Given this list of marker genes Jam3, Cd47, Pdgfd, Ager, Ccr2, here is a description of the gene set: studied in species Mus musculus Mouse Gene Set: GOBP_POSITIVE_REGULATION_OF_MONOCYTE_EXTRAVASATION Any process that activates or increases the frequency, rate or extent of monocyte extravasation.